Given this list of marker genes LAMA3, LAMC2, BTK, LAMB3, IL10RA, here is a description of the gene set: Human Gene Set: HP_PYODERMA Pyoderma studied in species Homo sapiens Any manifestation of a skin disease associated with the production of pus.